Given this list of marker genes AKR1C3, AKR1B1, ADH4, AKR1C1, AKR1C2, AKR1D1, AKR1A1, AKR7A2, AKR1C4, AKR1E2, AKR1B15, AKR1B10, here is a description of the gene set: Human Gene Set: GOMF_ALDOSE_REDUCTASE_NADPH_ACTIVITY studied in species Homo sapiens Catalysis of the reaction: an alditol + NADP+ = an aldose + NADPH + H+.